Given this list of marker genes TP53INP1, SP100, FOXRED2, PPM1K, SAMHD1, ARHGEF6, CITED4, ENAH, CHN2, RIGI, ELOVL1, PKN2, TTC9, FHIP1A, SDC2, ENTPD2, CRY2, RSAD2, FAM13A, CFLAR, ZNF395, SMOC2, PRDX6, DDI2, PPM1L (protein phosphatase, Mg2+/Mn2+ dependent 1L), RABEP2, PAQR7, BDH1, ZBTB8OS, CIDEC, LHFPL6, CFAP410, DHRS1, DDHD2, PEF1, SRSF4, AOC3, ACBD5, PINK1, TMEM59, WFDC21P, CPT2, GDPD1, LDLRAD3, CDS2, CUTALP, CACFD1 (calcium channel flower domain containing 1), EMC1, SNCG, AMY2B, EIF4E3, DAAM1, GDPD3, TRIM24, SLC22A4, RBP4, GOLGA2, SELENOI (selenoprotein I), GRK2, NFIC, CES1, ACSL1, G0S2, MINDY2, ARHGEF3, ACAD9, TAB2, ASIC1 (NCBI Gene Id 41), TMEM82, SMAD3, IFIH1, RBM39 (NCBI Gene Id 9584), SULT1A1, THAP3, MRTO4, RETNLB, DPH2, PCDHB15, IRAK2, LYPLA2, ARFRP1, RIMS3, INPP5B, CDC42EP3, RRAGC, MTFR1L, DNAJC8, PM20D1, DUOXA1, BLNK, SGCB, SERINC3, RXRA, FUCA1 (NCBI Gene Id 2517), EFHD1 (EF-hand domain family member D1), S100PBP, DHDDS, ITM2C, CFD, TSC22D3 (TSC22 domain family member 3), GRTP1, DDOST, MGA, RPA2, HSPH1, PADI2, PER2, SLC7A10, SYT13, TOB2, GRID2, AK2, TSPAN7, GALNT12, SYCE1, TMEM182, NHSL3, TXLNA, THBS4, FABP4, LTBP2, GAREM1, PHACTR1, TOB1 (NCBI Gene Id 10140), MAPK8IP1, CHMP4B (charged multivesicular body protein 4B), EPB41, EBNA1BP2, ZNF770, ZMPSTE24, CA3, MBP, PHYH, UQCRH, ENHO, ALCAM, AIFM2, GLCCI1, KIF5C, DUSP16, URM1, CCDC28B, SURF4, PPCS (phosphopantothenoylcysteine synthetase), TCF12, RCC2, RORC, REEP5, IQCC, BBOX1, RPS6KA1, CDO1, UROD, BTG1, KLHL26, ATP5IF1, VDR, MMACHC, LRRC1, EPB41L1, SMIM12, MKNK2, ZBTB40, AGO4, CDHR1, NCOA3, PRICKLE2, GBP6, SLC23A2, SCARF1, NNMT, EPHA2, SLC16A6, CAVIN1, PSMB2, CRIP2, CST3, AGO1, NDUFS5, TXNIP, SCP2, SVBP, CBX7, PROSER2, SP110, CXCL12, FOSL2, USP48, BACH2, EIF4G3, HERPUD1, LIN7C, PLB1, MICOS10, TOR3A, TNNT3, PPP1R8, ZBTB43, AFAP1L1, LENG9, TRAF1, VPREB1, SKI, KLF15, SLC25A29, HP1BP3, ADIPOQ, RHOU, PRPF38A, MUL1, UBE4B, NECAP2, PLEKHF1, ERRFI1, UPF2, ZFYVE9, DEDD2, PUM1, TCF4 (transcription factor 4), C5AR2, LALBA, NOTCH1, SMCR8, SPINT2, LRRC42, BSDC1, CDC40, FEM1C, USP20, GPC4, KDF1, MIB1, MADD, OAS2, CASZ1, GABPB1, KPNA6, TMEM35B, GGT6, DDO (NCBI Gene Id 8528), LY6D, PLIN4, ITM2B, SH3BP5, COX8BP (NCBI Gene Id 404544), RPL22, HEY1, FAM76A, TMTC2, FAM20A, C11orf54, SAP30, KLHDC7A, EPC2, SLC6A2, BSPRY, SETD5, NMNAT1, SCRG1, PELI2, CFB, TMEM54, PPM1B, MLLT3, PPFIBP2, CLSTN1 (NCBI Gene Id 22883), here is a description of the gene set: Human Gene Set: RAY_TUMORIGENESIS_BY_ERBB2_CDC25A_DN Down-regulated genes in breast tumors from transgenic mice overexpressing ERBB2 and CDC25A compared to those from mice overexpressing ERBB2 only. Checkpoint pathways help cells maintain genomic integrity, delaying cell cycle progression in response to various risks of fidelity, such as genotoxic stresses, compromised DNA replication, and impaired spindle control. Cancer cells frequently exhibit genomic instability, and recent studies showed that checkpoint pathways are likely to serve as a tumor-suppressive barrier in vivo. The cell cycle-promoting phosphatase CDC25A is an activator of cyclin-dependent kinases and one of the downstream targets for the CHK1-mediated checkpoint pathway. Whereas CDC25A overexpression is observed in various human cancer tissues, it has not been determined whether deregulated CDC25A expression triggers or promotes tumorigenesis in vivo. Here, we show that transgenic expression of CDC25A cooperates markedly with oncogenic ras or neu in murine mammary tumorigenesis. MMTV-CDC25A transgenic mice exhibit alveolar hyperplasia in the mammary tissue but do not develop spontaneous mammary tumors. The MMTV-CDC25A transgene markedly shortens latency of tumorigenesis in MMTV-ras mice. The MMTV-CDC25A transgene also accelerates tumor growth in MMTV-neu mice with apparent cell cycle miscoordination. CDC25A-overexpressing tumors, which invade more aggressively, exhibit various chromosomal aberrations on fragile regions, including the mouse counterpart of human 1p31-36, according to array-based comparative genomic hybridization and karyotyping. The chromosomal aberrations account for substantial changes in gene expression profile rendered by transgenic expression of CDC25A, including down-regulation of Trp73. These data indicate that deregulated control of cellular CDC25A levels leads to in vivo genomic instability, which cooperates with the neu-ras oncogenic pathway in mammary tumorigenesis. species: Mus musculus from publication Ray D, Terao Y, Fuhrken PG, Ma ZQ, DeMayo FJ, Christov K, Heerema NA, Franks R, Tsai SY, Papoutsakis ET, Kiyokawa H (PMID 17283130)